Given this list of marker genes Fam131b (NCBI Gene Id 76204), Ankib1, Cox11, Plpp6, Elavl1, Eya1, Add1, Wdr76, Tshz3, Tcf23, Fkbp8, Paxbp1, Xkr6, Nfe2, Osbpl6, Zfp426, Epb41l4a, Lrrc27, Tasl, Pdxk, Adcy9, Ebf2, Akap6, Taok1, Klf12, Fbxl7, Zfp128, Jhy, Alg5, Zmiz1, Cacna1b, Mixl1, Zscan21, Hmcn1, Ap1g1, here is a description of the gene set: species: Mus musculus from publication Chen Y, Wang X (PMID 31504780) Mouse Gene Set: MIR_6963_5P Genes predicted to be targets of miRBase v22 microRNA mmu_miR_6963_5p in miRDB v6.0 with MirTarget v4 prediction scores > 80 (high confidence targets).